Given this list of marker genes AKR1C1, CYP7A1, CYP27A1, AKR1C2, AKR1C3, HSD3B7, RXRA, CYP8B1, CYP7B1, AKR1C4, NCOA2, NCOA1, NR1H4, AKR1D1, here is a description of the gene set: studied in species Homo sapiens Synthesis of bile acids and bile salts via 27-hydroxycholesterol Human Gene Set: REACTOME_SYNTHESIS_OF_BILE_ACIDS_AND_BILE_SALTS_VIA_27_HYDROXYCHOLESTEROL